Given this list of marker genes ANO10, NDUFA1, KIF1C, POMT1, GAD1, COQ4, GRIN1, POLR1A, PIGU, CNTNAP2, LIPT1, XRCC4, SOX4 (SRY-box transcription factor 4), SLC39A8, SUMF1, NEUROD2, CTSF, MAPK8IP3, TMX2, CHP1, ATP5MK, PEX16, CRPPA, RBL2, KIF1A, PACS1 (NCBI Gene Id 55690), PNKP, ATP2B3, TK2, COG7, ATP13A2, NMNAT1, TBCD, COL4A1, LYST, AP4E1, L2HGDH, TARS1, GFAP, CRAT, HDAC4, TOP3A, SLC5A6, DHX9, CIZ1, PNPLA6, NODAL, SPTBN2, LONP1, PLP1, ATXN3, CLTC, CCDC88A, LMX1B, STXBP1, POGZ, ACO2, CUL4B, NDUFAF4, SLC39A14, BCL11A, ZPR1 (ZPR1 zinc finger), TBCK, SCN1A, ATP5F1A, CASK, ERCC6, SYNE1, TAF4, HK1, SYT14, CTCF, ATP1A2, EXOSC5, RELN, PPP2R2B, PLK4, KAT5, COQ5, QARS1, TXN2, RNF13, COL18A1, GLS, ZIC1, FKRP, SQSTM1, DEGS1, FDXR, ATP1A3, PI4KA, RNF216, GNAO1, MED27, AGTPBP1, GJB1, KCND3, MFF, WDR73, PEX10, KATNB1, LNPK, UBTF, MAG, PCLO, RORA, CKAP2L, VPS4A, SLC25A22, HSD17B4, TDP1, SLC13A3, PNPT1, ELOVL4, CTBP1, IFRD1, GON7, REPS1, PIGS, FOXRED1, EEF2, CCDC88C, FBXL4, GTPBP2, PIGG, NDUFA9 (NADH:ubiquinone oxidoreductase subunit A9), FARS2, SCN2A, ATCAY, FAR1, SIK1, LIG3, PRKCG, VPS53, TOR1A, MICOS13, KCNC1, TBC1D20, MRE11, SCN1B, TBC1D2B, TRAPPC6B, STT3B, RNF170, DNM1L, SCARB2, CAMLG, TRPC3, RUBCN, UBA5 (NCBI Gene Id 79876), PLCH1, POLA1, MFSD8, ATXN7, ATXN2, PEX6, ERCC8, ATP6V0A1, WDR81, ZIC2, ATP6AP2, PIK3R5, COG3, DCLRE1B, ERCC3, ATP5F1D, DNMT1, NDUFS1, ELOVL5, TWNK, NADK2, VPS13D, RFC1, VPS11, MAN2B1, FXN, SPTAN1, DMXL2, KCNJ10, MORC2, PIGK, BCAS3, DHX30, CHD8, GRN, ALG3, GRIK2, ARMC9, FA2H, NOTCH2NLC, ACY1, TTPA, FGF12, NOP56, IBA57, GEMIN5, NDUFA13, PIGA, POLR3B, TSEN2, ERCC2, PRRT2, MTHFS, CYFIP2, BCORL1, RNASEH1, VLDLR, STT3A, SDHA, MME, CERS1, SLC9A6, GDAP2, ATPAF2, NPTX1, ALDH5A1, SPART, ZMIZ1, KY, APTX, EXOSC3, CPLX1, C19orf12, YRDC, CLN5, NDE1, GRIA2, SLC35A2, LAMA2, COQ8A, TAF1, PLA2G6, SPG7, ZFHX3, NDUFS4, WARS2, MED11, RNF113A, PITRM1, TUBB, MPLKIP, RNU12, DNAJC3, TUBB2B, RARS2, SERAC1, POLG, DLG4, SH3TC2, ATAD3A, WDR4, CYB5A, NKX6-2, HERC1, CLPB, ACTL6B, MT-ATP8, SCO2, BCAP31, KCNMA1, TGM6, FKTN, COX20, FGF14, NUP214 (nucleoporin 214), BRAT1, FAT2, POLG2, SIL1, SLC44A1, NGLY1, HTT, TUBB4A, DAB1, BCS1L, SNAPC4, KCNA1, CWF19L1, COA7, HMBS, CACNA1G (NCBI Gene Id 8913), MYH3, PRUNE1, MECR, AP4S1, PIGP, FMR1, ZNF335, PCNA, SCN8A, POLR1C, ABCB7, SNF8, SCYL1, SAMD9L, AARS1, EMC1, DPM1, PTRH2, AFG3L2, POLR3K, SEMA6B, DHCR7, MVK, TBC1D24, NDUFA8, IFIH1, BEAN1, PLAA, TBP, SEPSECS, GNS, TECPR2, PMPCB, ABHD12, PIGN, SRPK3, CUX2, ARG1, GRID2, TTC19, FTH1, ATP8A2, KCNC3, SLC1A3, SC5D, TRAPPC4, INTS11, LETM1, SLC25A4, GTF2H5, TTBK2, PRDX3, NARS2, EBF3, DARS2, MRM2, ATP5F1E, KCTD7 (NCBI Gene Id 154881), FCSK, TRAPPC11 (trafficking protein particle complex subunit 11), PMPCA, ENSG00000288330, LAGE3, SNX14 (sorting nexin 14), SLC19A1, EXOSC9, COG6, LYRM7, TPP1, ALG9, CYP27A1, SLC33A1, COX4I1, IRF2BPL, SLC31A1, CACNA1A, ATXN10, COG8, SLC25A46, CACNA2D2, ZNHIT3, VWA3B, CARS2, VPS50, CDC42, AP4M1, TMEM240, SACS, PMM2, GRM1, TRMT1, COG1, DOHH, PLD3, SLC32A1, ADSL, SLC9A1, AP3B2, CYB5R3, OSGEP, SRD5A3, MT-ATP6, SLC35B2, COQ2, SETX, OPA1, CDKL5, GPAA1 (glycosylphosphatidylinositol anchor attachment 1), ATXN8OS, RRM2B, TBCE, CARS1, SNUPN, AARS2, YIF1B, GBA2, COQ9, ARF1, PRNP, RNASEH2A, POLR3A, FRRS1L, ARX, TRIM8, VARS1, MDH2, TEFM, CAPN1, HEPACAM, ABCD1, SPG21, PEX2, SHQ1, XRCC1, COG5, AP4B1, CLCN7, TSPOAP1, PIGT, ACBD6, SCAF4, EPRS1, CNP, MRPS34, SOD1, UCHL1, NFASC (NCBI Gene Id 23114), CLN8, STUB1, ARCN1, PIGQ, RTTN, UFM1, ATXN1, ALG1, MCOLN1, MGME1, ADPRS, GFM2, GTF2E2, HEXB (hexosaminidase subunit beta), BTD, CNTNAP1, MARS2, VPS41, WDR45 (NCBI Gene Id 11152), ATP6V1A, GRM7, NALCN, CAPRIN1, PDYN, EXOSC2, CTSD, DKC1, AIMP2, WWOX, CAMK2B, ITPR1, OPA3, here is a description of the gene set: Human Gene Set: HP_CEREBELLAR_ATROPHY Cerebellar atrophy studied in species Homo sapiens Cerebellar atrophy is defined as a cerebellum with initially normal structures, in a posterior fossa with normal size, which displays enlarged fissures (interfolial spaces) in comparison to the foliae secondary to loss of tissue. Cerebellar atrophy implies irreversible loss of tissue and result from an ongoing progressive disease until a final stage is reached or a single injury, e.g. an intoxication or infectious event.